The following is a description of a gene set: Human Gene Set: HP_BOWED_FOREARM_BONES A bending or abnormal curvature affecting either the radius, the ulna, or both. Bowed forearm bones studied in species Homo sapiens, and this is the list of marker genes: SCARF2, LAMA5, FGF23, LBR, VPS35L, CCN2, FGFR3, P3H1, IHH, PCNT, COL11A1, WNT7A, GDF5, CILK1, IFT43, COL2A1, SLC26A2, PRKG2, NPR2, ROR2, GLI3, B2M, TRPV4, RBM8A, POR, CHST3, HOXA11, FLNB, B3GALT6, SHOX, MMP13, FGFR2, TBX5, GNPNAT1, TMEM67, RIPK4, FLNA, RECQL4 (RecQ like helicase 4)